Given this list of marker genes Gdf3, Lrp6, Zic3, Foxa2, Ets2, Srf, Otx2, Hhex, Prickle1, Nodal, Lhx1, Wnt5a, here is a description of the gene set: species: Mus musculus The developmental process pertaining to the initial formation of the primitive streak from unspecified parts. The primitive streak is a ridge of cells running along the midline of the embryo where the mesoderm ingresses. It defines the anterior-posterior axis. Mouse Gene Set: GOBP_PRIMITIVE_STREAK_FORMATION